Given this list of marker genes SMAD6, SMAD5, SMAD2, SMAD7, SMAD9, SMAD3, HMGA2, SMAD4, SMAD1, here is a description of the gene set: studied in species Homo sapiens Human Gene Set: GOCC_SMAD_PROTEIN_COMPLEX A protein complex that consists of only SMAD proteins; may be homomeric or heteromeric. Heteromeric complexes act as transcription factors while homomeric complexes exist but are transcriptionally inactive. Hetero- versus homotrimerization is largely enthalpy driven.